The following is a description of a gene set: Mouse Gene Set: GOBP_DETECTION_OF_MECHANICAL_STIMULUS The series of events by which a mechanical stimulus is received and converted into a molecular signal. studied in species Mus musculus, and this is the list of marker genes: Igf1, Scn9a, Ano1, Trpa1, Pkdrej, Tmc1, Grm8, Itga2, Whrn, Pcdh15, Cav3, Strc, Mkks, Kcna1, Grin2d, Piezo1, Chrna10, Ntrk1, Bace1, Pkd2, Grin2a, Asic3, Il18, Cacnb3, Pkd1l1, Phf24, Kcnk2, Tlr4, Scn10a, Grin2b, Scn11a, Ptprq, Htr7, Ttn, Cxcl12, Jup, Cxcr4, Kcnk4, Lhfpl5 (lipoma HMGIC fusion partner-like 5), Pdzd7, Myc, Col11a1, Chrna5, Tcap, Pjvk, Sox2, Pkd1l3 (polycystic kidney disease 1 like 3), Pkd2l1, Tmc2, Piezo2, Fyn, Tmem87a, Htr2a, Serpine2, Tmem120a, Pkd1l2, Atp2b2, Adgrv1, Tnf, Hpn, Asic2, Scn1a (sodium channel, voltage-gated, type I, alpha), Chrna9, Slc12a2, Pkd1, Pkd2l2, Ano3, Rest, Pawr, Csrp3, Kcnq1, Kit